The following is a description of a gene set: The migration of cells in the telencephalon from the subventricular zone to the olfactory bulb in which cells move orthogonally to the direction of radial migration and do not use radial glial cell processes as substrates for migration. Human Gene Set: GOBP_TANGENTIAL_MIGRATION_FROM_THE_SUBVENTRICULAR_ZONE_TO_THE_OLFACTORY_BULB species: Homo sapiens, and this is the list of marker genes: OGDH, SRF (serum response factor), RAC1, SLIT2, LRRK2, SLIT3, SLIT1, ROBO1, ARX